Given this list of marker genes ADAMTS15, ZEB2, SLC25A10, MECOM, AKT1, MDFIC, NAA10, SPECC1L, LYN, FOCAD, PIK3CA, PTEN, EDEM3, TBX1, NSD1, ADAMTS3 (NCBI Gene Id 9508), PIGL, PIEZO1, SETD1A, MOGS, FLT4, KMT2D, GJC2, APC2, ZMYM2, THSD1, PIGN, VEGFC, EP300, ATAD3A, PEX11B, CREBBP, ANGPT2, DPH2, SOX18, EZH2, here is a description of the gene set: studied in species Homo sapiens Hydrocele testis Human Gene Set: HP_HYDROCELE_TESTIS Accumulation of clear fluid in the between the layers of membrane (tunica vaginalis) surrounding the testis.